The following is a description of a gene set: Abnormal lacrimal gland morphology Human Gene Set: HP_ABNORMAL_LACRIMAL_GLAND_MORPHOLOGY Abnormality of the lacrimal gland, i.e., of the almond-shaped gland that secretes the aqueous layer of the tear film for each eye. species: Homo sapiens, and this is the list of marker genes: BTNL2, GJB2, SLC25A24, GJB6, FGF10, FGFR2, FOXL2, SOX10, FGFR3, HLA-DRB1